The following is a description of a gene set: Mouse Gene Set: GOBP_VERY_LONG_CHAIN_FATTY_ACID_CATABOLIC_PROCESS species: Mus musculus The chemical reactions and pathways resulting in the breakdown of a very long-chain fatty acid. A very long-chain fatty acid has an aliphatic tail containing more than 22 carbons., and this is the list of marker genes: Abcd2, Slc27a2, Abcd1, Abcd4, Slc27a4, Abcd3 (NCBI Gene Id 99893), Acox1